Given this list of marker genes CSNK2B, PIP5K1B, CSNK2A1, DVL1, CSNK2A2, CSNK1E, DVL3, DVL2, here is a description of the gene set: Reactome Pathway: WNT mediated activation of DVL species: Homo sapiens part of: TCF dependent signaling in response to WNT The three human Dishevelled (DVL) proteins play a central and overlapping role in the transduction of the WNT signaling cascade. DVL activity is regulated by phosphorylation, although the details are not completely worked out. DVL likely exists as a phosphoprotein even in the absence of WNT stimulation, and is further phosphorylated upon ligand binding. Casein kinase 1epsilon (CSNK1E), casein kinase 2 (CSNK2) and PAR1 have all been reported to phosphorylate DVL. Upon pathway activation, phosphorylated DVL translocates to the plasma membrane through an interaction between the DVL PDZ domain and the FZD KTxxxW motif. At the plasma membrane, DVL is believed to oligomerize through its DIX domain, providing a platform for AXIN recruitment; recruitment of AXIN is also facilitated by interaction with LRP. DVL interacts with phosphatidylinositol-4-kinase type II (PI4KII) and phophatidylinositol-4-phosphate 5-kinase type I (PIP5KI) to promote formation of phosphatidylinositol 4,5-bisphosphate (PI(4,5)P2) in the membrane, which is required for the clustering and phosphorylation of LRP6 and the recruitment of AXIN.